Given this list of marker genes Ldah, Atg7, Pnpla3, Ces1g, Mttp, Abca3, Lamtor1, Mtch2, Pnpla2, Lima1, Nr1d1, Slc25a46, Cert1, Cav3, Apoa2, Mir33, Hpn, Tsku, Lcat, Fabp4 (fatty acid binding protein 4, adipocyte), Slc25a27, Npc1l1, Sesn2, Rtn4, Soat2, Ins2, Ces1a, Hps6, Apoe, Xbp1, Tmem97, Mlxipl, Commd1, Pla2g10, Adrb1, Thada, Nr5a2, Gip, Tm6sf2, Tspo, Pnlip, Tlcd1, Nus1, Gramd1b, Fundc2, Apob, Gpam, G6pc1, Angptl3, Ccdc22, Pex2, Trem2, Cln8, Nfe2l1, Insig1, Ces1b, Ephx2, Commd9, Abca2, Map2k1, Lrp5, Lipc, Abhd8, Pcsk9, Mtln, Apoc3, Ddx3x (NCBI Gene Id 236681), Abcg8, Apoa5, Rora, Slc37a4, Bloc1s6, Got1 (glutamic-oxaloacetic transaminase 1, soluble, NCBI Gene Id 14718), Pkp2, Tlcd3b, Npc1, Lpl, Tlcd2, Hnf4a, Rcn3, Pnpla5 (patatin-like phospholipase domain containing 5), Ces1e, Raly, Nr1h2, Gpr39, Negr1, Or10j5, Prkaa2 (NCBI Gene Id 66516), Ncor1, Tlcd4, Hdac9, Fundc2b, Nr1h3, Mir124a-1hg, Minar2, Usf1, Adora1, Cav1, Ldlr, Lyst, Mylip, Tlcd3a, Apoc2l, Ins1, Abhd5, Dgat1, Soat1, Fabp3, Angptl8, Npc2, Cd24a, Etnppl, Ldlrap1, Il18, Washc5, Apoc4 (NCBI Gene Id 11425), Asgr2, Slco1a6, Pnpla1, Alms1, Scarb1, Abca12, Ttc39b, Plscr3, Pla2g12b, Cyp39a1, Apoa1, Zbtb20, Srebf2, Scd1, D1Pas1, Errfi1, Nr1h4, Enpp7, Lncbate1 (NCBI Gene Id 77187), Pnpla8, Mia2, Dgat2, Ttc39d, Ehd1, Fgfr4, Tgfb1, Abhd4, Ormdl2, Mexis, Gpihbp1, Ampd2, Malrd1, Gck, Pnliprp1, Hsdl2, Adck1, Ormdl1 (NCBI Gene Id 252836), Acaca, Abcg1, Usf2, Abcb4, Ces1f, Apoa4, Gckr, Hps1, C1qtnf3, Osbpl8, Cyp7b1, Pnliprp2, Pold1, Apoc2, Cyp7a1, Lipg, Abcb11, Sec24a, Rbp1, Sar1b, Cebpa (NCBI Gene Id 12606), Abcd1, Sirt1, Itgb6, Angptl4, Abca5, Abca1, Nr1d2, Lipa, Ces1c, Prkaa1, Surf4 (surfeit gene 4), Abcg5, Ormdl3, Fitm2, Med13, Atp13a2, Acox1, Abcg4, Ces1d, Ces1h, here is a description of the gene set: species: Mus musculus Mouse Gene Set: GOBP_LIPID_HOMEOSTASIS Any process involved in the maintenance of an internal steady state of lipid within an organism or cell.